The following is a description of a gene set: A loss of myelin from the internode regions along myelinated nerve fibers of the peripheral nervous system. studied in species Homo sapiens Peripheral demyelination Human Gene Set: HP_PERIPHERAL_DEMYELINATION, and this is the list of marker genes: NEFL, TYROBP, NFU1, GNB4, LITAF, MT-ND4, MT-ND6, FA2H, MT-ND1, PSAP, MMACHC, CTDP1, PEX16, SURF1, SBF2, SH3TC2, MT-ND2, SPTBN1, MPZ (NCBI Gene Id 4359), MOCS2, GALC, MT-ATP6, LRPPRC, ABCA1, PRPS1, MT-TK, HK1, MAT1A, GCDH, PLP1, DNM2, MT-ND3, GBF1, MT-TL1, MT-TW, MTTP, NDRG1, MT-ND5, EGR2, PRX, PMP2, PMP22, MOCS1, FLVCR1, SOX10, ARSA (NCBI Gene Id 410), MT-TV, SUMF1, GDAP1, ARHGEF10, KIF1C, COQ7, UBTF